Given this list of marker genes Grpel2, Romo1, Timm50, Timm10, Phb2, Smdt1, Afg3l1, Chchd6, Immt, Dnajc19, Immp1l, Apoo, Timm9, Spg7, Immp2l, Chchd10, Pdss1, Micu2, Apool, Micu3, Timm44, Timm22, Timm17b, Phb1, Micu1, Timm23, Micos10, Grpel1, Timm21, Timm10b, Timm17a, Pam16, Micos13, Dnajc15, Trmt10b, Mcub, Agk (NCBI Gene Id 77076), Mcu, Chchd3, Timm29, Pdss2, Dnajc11, Afg3l2, here is a description of the gene set: studied in species Mus musculus Mouse Gene Set: GOCC_INNER_MITOCHONDRIAL_MEMBRANE_PROTEIN_COMPLEX Any protein complex that is part of the inner mitochondrial membrane.